Given this list of marker genes CCND2, FOS, STAT3, CDC20, MKI67, CD63, HMOX1, SPP1, REV3L, TPM4, TPM1, SDC3, YBX1, RPS27L, DBI, MARCKSL1, PCNA, HNRNPA1L2, HLA-DRB1, NIN, MCM2, KLF6, CDK1, MCM3, OST4, EEF1A1, PLK1, FRMD8, C1orf159, FTL, EPN2, CD9, CCND1, CDC42SE1, PPP1R14B, RRM2, SERPINE2, PBK, CDK4, RNF213, HMGB2, DYNLT1, HSPA14, SULF2, RPLP0, TAGLN2, PPFIBP1, FN1, TMEM176B, PPP1R18, CHST11, MARCKS, B2M (beta-2-microglobulin), PDGFRA, MCAM, TOP2A, LGALS1, here is a description of the gene set: Human Gene Set: JOHANSSON_GLIOMAGENESIS_BY_PDGFB_UP Genes up-regulated in brain tumors induced by retroviral delivery of PDGFB. from publication Johansson FK, Göransson H, Westermark B (PMID 15750623) Retroviral tagging previously identified putative cancer-causing genes in a mouse brain tumor model where a recombinant Moloney murine leukemia virus encoding the platelet-derived growth factor B-chain (MMLV/PDGFB) was intracerebrally injected in newborn mice. In the present study, expression analysis using cDNA arrays revealed several similarities of virus-induced mouse gliomas with human brain tumors. Brain tumors with short latency contained on average 8.0 retroviral insertions and resembled human glioblastoma multiforme (GBM) whereas long-latency gliomas were of lower grade, similar to human oligodendroglioma (OD) and had 2.3 insertions per tumor. Several known and novel genes of tumor progression or cell markers were differentially expressed between OD- and GBM-like tumors. Array and quantitative real-time PCR analysis demonstrated elevated expression similar to Pdgfralpha of retrovirally tagged genes Abhd2, Ddr1, Fos, Ng2, Ppfibp1, Rad51b and Sulf2 in both glioma types compared to neonatal and adult normal brain. The retrovirally tagged genes Plekhb1, Prex1, Prkg2, Sox10 and 1200004M23Rik were upregulated in the tumors but had a different expression profile than Pdgfralpha whereas Rap1gap, Gli1, Neurl and Camk2b were downregulated in the tumors. The present study accentuates the proposed role of the retrovirally tagged genes in PDGF-driven gliomagenesis and indicates that insertional mutagenesis can promote glioma progression. studied in species Mus musculus